The following is a description of a gene set: Any process that results in a change in state or activity of a cell or an organism (in terms of movement, secretion, enzyme production, gene expression, etc.) as a result of a salt stimulus. Human Gene Set: GOBP_RESPONSE_TO_SALT species: Homo sapiens, and this is the list of marker genes: HSF1, ALPL, DAXX, ZC3H12A, NEFL, RNLS, HNRNPA1, TGFB1, MAPK13, PHEX, SLC26A5, RUNX2, EDNRB, FGF23, FGFR1, COMT, ABCC6, EDN1, HNRNPD, ANKH, SLC12A3, XPO1, NPR2 (NCBI Gene Id 4882), DAB2 (NCBI Gene Id 1601)